Given this list of marker genes Cacng3, Anp32e, Efnb3, Akap9, Gabra4, Dcc, Nptx2, Kcnk2, Dlg2, Olfm1, Nlgn2, Nectin3, Chrna9, Abhd17c, Cdh2, Dagla, Lrfn1, Ptpro, Rgs9, Slitrk3 (SLIT and NTRK-like family, member 3), Igsf21, Igsf9, Epha4, Cnksr2, Grin2c, Mkln1, Grin2b, Actn2, Dlg3, Chrnb2, Syndig1, Dlg1, Dgki, Nlgn3, Slc30a1, Slitrk1, Grid2, Celsr3, Gsg1l, Hspa8, Mpp2, Nlgn1, Prrt1, Il1rapl1, Cacng4, Itga8, Adra2a, Fgf22, Stx1a, Lrrc4b, Efnb2, Abhd17a, Vdac1, Lin7c, Kcnt1, Rtn4, Nptn, Lrrtm3, Cacng5, Gabra3, Chrnb1, Grik5, Elfn2, Asic2, Grin2d, Robo2, Grm1, Slc16a7, Sorcs3 (sortilin-related VPS10 domain containing receptor 3), Glra1, Lrrtm4, Pacsin1, Grid1, Drd3 (dopamine receptor D3), Lin7b, Lrp1, Trappc4, Sema4f, Gria1, Nlgn4l, Lrrc7, Ptprs, Gabrb3, Gpr158, Afdn, Adam22, Notch1, Rapsn, Glra3, Cacng2, Lin7a, Sorcs2, Lrrc4c, Lrp8, Lrrtm1, Gabrg2, Lrfn5, Gria2, Kcnab2, Chrna4, Chrna10, Grin3b, Lrfn2, Scrib, Gabra2, Igsf11, Slc12a5, Vangl2, Tmem108, Plppr4, Epha7, Neto1, Chrne, Gabra6, Clstn1, Grik1, Kcnd2, Elfn1, Nsg2, Htr5a, Neo1, Rnf10, Sema4b, Slitrk5 (SLIT and NTRK-like family, member 5), Ryk, Grik4, Dlg4, Lzts1, Neto2 (NCBI Gene Id 74513), Lrfn4, Oprd1, Sigmar1, Asic1 (acid-sensing ion channel 1), Grik3 (glutamate receptor, ionotropic, kainate 3), Prr7, Abhd17b, Gabrb2, Ptprf, Grik2, Lrrtm2, Cacna1c, Cacng8, Gabra1, Grin1, Erbb4, Dgkb, Ptprt, Tiam1, Ptprz1, Csmd2, Shisa7, Cdh10, Iqsec2, Slc16a3, Prrt2, Crhr1, Cyth2 (NCBI Gene Id 19158), Sema4c, Kcnh1, Clstn3, Nrg1, Chrna1, Lrfn3, Glra4, Lrrc4, Shisa9, Olfm2, Chrna3, Chrnd, Gabrb1, Adgrb3, Atp2b2, Grin2a, Arc, Gabra5, Tmem240, Chrm4, Cacng7, Chrna7, Gria4, Kcnb1, Adcy1, Glra2, Clstn2, Rgs7bp, Drd5, Shisa6, Cnih2, Adra2c, P2rx6, Hspb1, Gria3, Chrnb4, Scn8a, Nrcam, Chrm3, Kcnd3, Grin3a, Grm5, Chrm1, here is a description of the gene set: studied in species Mus musculus Mouse Gene Set: GOCC_POSTSYNAPTIC_SPECIALIZATION_MEMBRANE The membrane component of the postsynaptic specialization. This is the region of the postsynaptic membrane in which the population of neurotransmitter receptors involved in synaptic transmission are concentrated.